Given this list of marker genes Ptpn3, Clcn2, Ank3, Gja5 (NCBI Gene Id 70659), Rangrf, Cav3, Slmap, here is a description of the gene set: Any process that modulates the rate, frequency or extent of membrane depolarization during an action potential. Membrane depolarization is the process in which membrane potential changes in the depolarizing direction from the resting potential. Mouse Gene Set: GOBP_REGULATION_OF_MEMBRANE_DEPOLARIZATION_DURING_ACTION_POTENTIAL species: Mus musculus